Given this list of marker genes APOBEC3A, PDF, GNPDA1, KLK3, PGLYRP1, ADAT1, MBLAC2, NIT2 (nitrilase family member 2), MTHFD2L, PM20D2, NDST1, SIRT6, DPYSL3, AMPD1, HDAC8, AFMID, APOBEC3H, FHIT, CRMP1, DCLRE1B, AGA, DPYSL4, PGLYRP2, GLS, APOBEC2, ADARB1, FAAH, DARS1, AICDA (NCBI Gene Id 57379), FAAH2, UPB1, OPLAH, APOBEC3F, RIDA, ASPG, HINT3, ASAH2, NIT1, CD101, ADA2, NAALAD2, PADI6, CDADC1, GLS2, GNPDA2, TGM2, HDAC4, ARG2 (arginase 2), ACY3, HDAC10, CAT, ASAH2B, CDA, HDAC2, ACER1, HDAC11, HINT1, PARK7 (Parkinsonism associated deglycase), ADARB2, ALLC, AMDHD2, MAPDA, DDAH1, HDAC6, APOBEC3C, SIRT4, MTHFD1 (methylenetetrahydrofolate dehydrogenase, cyclohydrolase and formyltetrahydrofolate synthetase 1), ADAR, DPEP1, ADAT3, ASAH1, SIRT1, SIRT5 (sirtuin 5), VNN2, ASPA, PM20D1, NDST2, PIGL, NTAN1, PADI4, ARG1, DDAH2, DPYS, NAAA, ZBP1, GCH1, SIRT2, AMPD2, HDAC7, PADI1, PADI2, ACER2, CAD, ACY1, ACR, APOBEC3B, NGLY1, DPYSL5, HDAC5 (NCBI Gene Id 23342), NDST4, AMPD3, PADI3, ATIC, HDAC9, BTD, AMDHD1, MTHFD2, HDAC3, ACER3, APOBEC3D, ADAD2, DPYSL2, APOBEC3G (NCBI Gene Id 80065), AGMAT (agmatinase (putative)), APOBEC1, LACC1, GCHFR, ADA, ASRGL1, PGLYRP3, DCTD, ADAT2, DHODH, VNN1, HINT2, HDAC1 (histone deacetylase 1), GDA, ADAD1, DCLRE1A, NTAQ1, NADSYN1, PGLYRP4, here is a description of the gene set: Catalysis of the hydrolysis of any carbon-nitrogen bond, C-N, with the exception of peptide bonds. studied in species Homo sapiens Human Gene Set: GOMF_HYDROLASE_ACTIVITY_ACTING_ON_CARBON_NITROGEN_BUT_NOT_PEPTIDE_BONDS